Given this list of marker genes Prss29, 9130008F23Rik, Asf1b, St8sia6, Zbed6, Cmtm3, Arhgdig, Coprs, Ccdc62, Hcfc1 (host cell factor C1), Rbbp8, Ankrd7, Smim14, Smarca4, Bcor, Ccdc24, Hs3st6, Akap3, Suv39h1, Prss28, Grn, Pemt, Necab1, Stmn3, Suds3, Ppp4r4, Phf6, Ndufa2, Crxos, Plpp4, Lpar6, Slc25a34, Ctr9, Tbl1xr1 (transducin (beta)-like 1X-linked receptor 1), Ube2a, Slc35e2, Fbll1, Zfp14, Smarcb1, Zfp420, here is a description of the gene set: species: Mus musculus The developmental process in which an organism emerges from a surrounding protective structure such as an egg or pupa case. Mouse Gene Set: GOBP_ORGANISM_EMERGENCE_FROM_PROTECTIVE_STRUCTURE